The following is a description of a gene set: Reactome Pathway: mTORC1-mediated signalling part of: MTOR signalling mTORC1 integrates four major signals – growth factors, energy status, oxygen and amino acids – to regulate many processes that are involved in the promotion of cell growth. Growth factors stimulate mTORC1 through the activation of the canonical insulin and Ras signaling pathways. The energy status of the cell is signaled to mTORC1 through AMP-activated protein kinase (AMPK), a key sensor of intracellular energy status. Energy depletion (low ATP:ADP ratio) activates AMPK which phosphorylates TSC2, increasing its GAP activity towards Rheb which reduces mTORC1 activation. AMPK can reduce mTORC1 activity by directly phosphorylating Raptor. Amino acids positively regulate mTORC1. In the presence of amino acids, Rag proteins bind Raptor to promote the relocalization of mTORC1 from the cytoplasm to lysosomal membranes where it is activated by Rheb. Translocation of mTOR to the lysosome requires active Rag GTPases and a complex known as Ragulator, a pentameric protein complex that anchors the Rag GTPases to lysosomes. Rag proteins function as heterodimers, consisting of GTP-bound RagA or RagB complexed with GDP-bound RagC or RagD. Amino acids may trigger the GTP loading of RagA/B, thereby promoting binding to raptor and assembly of an activated mTORC1 complex, though a recent study suggested that the activation of mTORC1 is not dependent on Rag GTP charging. The activity of Rheb is regulated by a complex consisting of tuberous sclerosis complex 1 (TSC1), TSC2, and TBC1 domain family member 7 (TBC1D7). This complex localizes to lysosomes and functions as a GTPase-activating protein (GAP) that inhibits the activity of Rheb. In the presence of growth factors or insulin, TSC releases its inhibitory activity on Rheb, thus allowing the activation of mTORC1. studied in species Homo sapiens, and this is the list of marker genes: RHEB, RPTOR, SLC38A9, EIF4G1, EIF4EBP1, RRAGD, RPS6, LAMTOR4, LAMTOR5, MTOR, LAMTOR3, RRAGC, EIF4E (eukaryotic translation initiation factor 4E), AKT1S1, MLST8, EEF2K, EIF4B, RRAGB, LAMTOR2, RRAGA, FKBP1A, RPS6KB1, LAMTOR1 (late endosomal/lysosomal adaptor, MAPK and MTOR activator 1)